Given this list of marker genes Madd, Mgarp, Spg7, Hsbp1, Bloc1s5, Armcx3, Kif5c, Rab27b, Zc3h14, Kif21a, Bsn, Hdac6 (NCBI Gene Id 20374), Agtpbp1, Sod1, Dync1i1, Sybu, Kif1b, Hap1, Ranbp1, Pafah1b1 (platelet-activating factor acetylhydrolase, isoform 1b, subunit 1), Bloc1s4, Neto1, Uchl1, Ap3m2, Bloc1s6, Ap3d1, Kif3a, Snapin, Mapk8ip3, Ap3b1, Hif1a, Kif5b, Arl8b, Bloc1s3, Bloc1s2, Spast, Arl8a, Ap3s1, Dynll1, Hspb1, Map1a, Ap3s2, Nefl, Tmem108, Trim46, Ap3m1, Dlg2, Ndel1, Rab21, Kif1a, Bloc1s1, Ap3b2, Caly, Agbl4, Rangap1 (NCBI Gene Id 97970), Dtnbp1, Dst (dystonin), Kif5a, here is a description of the gene set: Mouse Gene Set: GOCC_AXON_CYTOPLASM Any cytoplasm that is part of a axon. species: Mus musculus